Given this list of marker genes GAB1, FGF1, FRS2, POLR2I, POLR2G, POLR2L, PIK3CA, FGF20, FGF16, POLR2B, POLR2J, POLR2E, FGF17, GRB2, FGF22, HRAS, KRAS, FGF8, PLCG1, FGFR2, NCBP1 (nuclear cap binding protein subunit 1), PIK3R1, FGF7, FGF6, POLR2H, FGF10, FGF3 (NCBI Gene Id 2248), FGF2, POLR2A, FGF9, POLR2F, POLR2K, GTF2F2, FGF18, FGF5, POLR2C, NCBP2, FGF23, SOS1, FGF4, POLR2D, GTF2F1, NRAS, here is a description of the gene set: part of: Signaling by FGFR in disease Reactome Pathway: Signaling by FGFR2 in disease The FGFR2 gene has been shown to be subject to activating mutations and gene amplification leading to a variety of proliferative and developmental disorders depending on whether these events occur in the germline or arise somatically. Activating FGFR2 mutations in the germline give rise to a range of craniosynostotic conditions including Pfeiffer, Apert, Jackson-Weiss, Crouzon and Beare-Stevensen Cutis Gyrata syndromes. These autosomal dominant skeletal disorders are characterized by premature fusion of several sutures in the skull, and in some cases also involve syndactyly (abnormal bone fusions in the hands and feet). <br><br>Activating FGFR2 mutations arising somatically have been linked to the development of gastric and endometrial cancers. Many of these mutations are similar or identical to those that contribute to the autosomal disorders described above. Notably, loss-of-function mutations in FGFR2 have also been recently described in melanoma. FGFR2 may also contribute to tumorigenesis through overexpression, as FGFR2 has been identified as a target of gene amplification in gastric and breast cancers. studied in species Homo sapiens